The following is a description of a gene set: studied in species Homo sapiens Any process that results in a change in state or activity of a cell or an organism (in terms of movement, secretion, enzyme production, gene expression, etc.) as a result of a corticosteroid hormone stimulus. A corticosteroid is a steroid hormone that is produced in the adrenal cortex. Corticosteroids are involved in a wide range of physiologic systems such as stress response, immune response and regulation of inflammation, carbohydrate metabolism, protein catabolism, blood electrolyte levels, and behavior. They include glucocorticoids and mineralocorticoids. Human Gene Set: GOBP_RESPONSE_TO_CORTICOSTEROID, and this is the list of marker genes: EPO, SMYD3, AGL, UBE2L3, SLIT2, COMT, IGFBP7, GHR, CPN1, IL22, ANXA1, CAD, DUSP1, FOS, TAT, PCNA, SCNN1B, SCGB1A1, OXT, PTPRC, AREG (NCBI Gene Id 727738), HDAC3, ADAM9, FOSL2, ALAD, EDN1, FOXO3, NPAS4, CALCR, GHSR, SH3RF1, SLC12A3, GPER1, STK39 (serine/threonine kinase 39), CCND1, MYOD1, PIK3CA, CYBB, ADIPOQ, POR, PRKCA, REST, DDIT4, UCP3, BCL2, METTL21C, HCN2, TGFB1, ERRFI1, EIF4E, HMGCS2, CDO1, TFAP4, IL1RN, IL6, LCAT, UCN, BMP6, KRAS, ZFP36L1, NTRK3, SCNN1A, CARD9, IL10, ABCB1, SSTR5, AKR1C3, BGLAP, GSK3A, MDK, PTGDS, CASP3, NR3C1, PDCD7, PRKN, KLF9, S100B, BCL2L11, SCNN1D, CLDN1, WNT7B, SOX30, MAP2K1, FBXO32, GHRHR, SCNN1G, MSTN, CYBA, NEFL, MT-ND3, PCK1, CSN1S1, CFLAR, HSD11B2, GLB1, CRH, ASS1, GBA1, GPR83 (G protein-coupled receptor 83), AQP1, ABCA3, HMGB1, UCN3, FLT3, ATP5F1A, CPS1, SLIT3, RAN, USP8, CEBPA, STC1, CASP9, FOSB, PDX1, TRIM63, ISL1, SSTR4, FECH, PTPRU (protein tyrosine phosphatase receptor type U), GSTP1 (NCBI Gene Id 2950), BMI1, CBX3 (chromobox 3), CALM3, JAK2, BCHE, SRD5A1, AANAT, TNF, PARP1, PCK2, HNRNPU (heterogeneous nuclear ribonucleoprotein U), GOT1, ZFP36L2, SSTR2, GKN2, RPS6KB1, INHBA, AIFM1, ETNPPL, ZFP36, UCP2, ACSBG1, TBX2, HDAC6, ZNF764, AXIN2, ALPL, AVPR1A, SGK1, SERPINF1, IGFBP2, FAM107A, FKRP